The following is a description of a gene set: Catalysis of the reaction: NAD(P)H + H+ + O2 = NAD(P)+ + hydrogen peroxide. Mouse Gene Set: GOMF_NAD_P_H_OXIDASE_H2O2_FORMING_ACTIVITY species: Mus musculus, and this is the list of marker genes: Fmo5, Kmo, Aifm1, Duox2, Txnrd1, Cyb5r4, Nox4 (NCBI Gene Id 50490), Mical1, Nox1, Mical2